The following is a description of a gene set: studied in species Homo sapiens Human Gene Set: GSE11961_FOLLICULAR_BCELL_VS_GERMINAL_CENTER_BCELL_DAY40_UP Genes up-regulated in follicular B cells versus day 40 germinal center B cells. from publication Kaji T, Ishige A, Hikida M, Taka J, Hijikata A, Kubo M, Nagashima T, Takahashi Y, Kurosaki T, Okada M, Ohara O, Rajewsky K, Takemori T (PMID 23027924) To obtain insight into the genetic basis of the increase of functional activity of memory B cells over time, we compared the gene expression profiles of day 7 and day 40 NP-specific/IgG1 memory B cells, GC B cells and plasma cells in immunized WT mice and naïve B cells, before and after activation in vitro., and this is the list of marker genes: PITPNC1, KRBA1, RAB37, C2orf68, RASL11B (RAS like family 11 member B), KLRC3, ATP6V0A2, ALKBH3, OTULINL, MFSD6, CYRIA, SNAI3-AS1, DEXI, PDE1C, ADAMTS7, FCRL1, SKOR1, MUTYH, DGKD, SCFD2, SLC25A36, CUX1, GABARAPL2, LDB2, BSCL2, PREX1, EPS8L1, PACS1, LANCL1, ZRANB1, PCSK1, ELK4, FRY, LCMT1, ALDH1B1, MANSC1, ARMC3, SNAPC5, PIK3IP1, LCK, CAMK2G, BPHL, D2HGDH, RAB33A, OVGP1, MTMR9, GYS1, KRAS, COA4 (cytochrome c oxidase assembly factor 4 homolog), MYADM, ERCC4 (NCBI Gene Id 7509), KCTD2, C11orf54, KIF21B, TSPAN2, ARL4C, MYO3B, FAM204A, P2RX6, IL20RA, GSAP, USF2, CD72, HAGH, MAK, MAD2L1BP, GAMT, ITGB2, NUDT12, SPPL3, LYPD6B, NXNL2, CD151, INPP4A, PTPN12, MXD4, SIRT5, CCDC89, SOX4, GGA3, TRIM24, ACOX1, DAP, PLGRKT, HEBP2, SNAPIN, TCF7, ZFP82, YWHAB, FAM227A, PPM1F, ARPC5L (NCBI Gene Id 81873), ITM2A (integral membrane protein 2A), S1PR5, ABCG1, SNTB2, CEP120, HSD17B11, TSC22D1, LTK, PRKCB, PDCD4, ZFP36L2, TMEM9B, DKKL1, STK38, RDH12, TPP1, NALF1, MKNK2, LTA4H, ETFRF1, ANAPC2, MATCAP1, C8orf58, ZNF512B, SELENBP1, TET1, RGS2, DCAF17, SIX5, SLC22A2, VIM, SORD, ITGAE (integrin subunit alpha E, NCBI Gene Id 3682), INPP5K, NAV3, LGALS4, ATP11B, CLIP4, SGSH, CD2, IFTAP, ZNF839, FMO5, DDHD1, SOCS2, ANKRD16, DNMT3A, PRKAB1, WDR45, MKRN2, GATA3, CALHM2, RNASEL, TMEM176A, CHD9, L1CAM, JAK1, MOB3A, MDM4, INSR, DDC, CLK2, NRBF2, ST6GALNAC6, ATG4B, ADGRE5, CCDC62, RETREG3, CNTROB, HAGHL, SGK1, TNFAIP8L2, ICA1L, TAX1BP3, KCTD1, POTEH, GM2A, ZNF322, GRK4, GPS2, S100PBP, KIFAP3, ASH1L, SNX20, EEF2K, SLC2A8, AGA, CD1D, SSBP2, RASGEF1A, ESYT2, EPHX1, CLDN16 (claudin 16), MIDEAS, PHYHD1, RNF170, BAZ2B, XPA, GNAI2, CYB5R3, ASB3, EPM2AIP1, KLHL24, PNISR, IQGAP1, CERS5, SLAMF6, RASL12